Given this list of marker genes Brd1, Kat6b, Brpf3, Kat7, Meaf6, Kat6a, Brpf1, Ing5, here is a description of the gene set: studied in species Mus musculus A multisubunit complex that catalyzes the acetylation of histone H3. Mouse Gene Set: GOCC_H3_HISTONE_ACETYLTRANSFERASE_COMPLEX